The following is a description of a gene set: During acute viral infections, naïve CD8+ T cells differentiate into effector CD8+ T cells and, after viral control, into memory CD8+ T cells. Memory CD8+ T cells are highly functional, proliferate rapidly upon reinfection and persist long-term without antigen. In contrast, during chronic infections, CD8+ T cells become “exhausted” and have poor effector function, express multiple inhibitory receptors, possess low proliferative capacity, and cannot persist without antigen. To compare the development of functional memory T cells with poorly functional exhausted T cells, we generated longitudinal transcriptional profiles for each. Genes down-regulated in CD8 T cells: naïve versus effectors at day 15 after acute infection with LCMV-Armstrong. Human Gene Set: GSE41867_NAIVE_VS_DAY15_LCMV_ARMSTRONG_EFFECTOR_CD8_TCELL_DN from publication Doering TA, Crawford A, Angelosanto JM, Paley MA, Ziegler CG, Wherry EJ (PMID 23159438) studied in species Homo sapiens, and this is the list of marker genes: GTF2B, TBC1D9, INPP5K, ITCH, TECPR1, HIPK1, DDX3X, HPS1, LIPC, POM121, RPS29, PHF20L1, HIP1R, MAP2K6, ANKS3, ARHGAP31, SAFB2, FRS2, ZNF598, EXD2, LMBR1L, DDA1, DMD, PSTPIP1, TFIP11, CAMK4, LAIR1, UAP1, RALGDS, CDYL2, PANK4, BTBD8, TMCC3, MED13, EDC4, ANKS1A, FOXJ2, LDLRAD3, RCHY1, ARHGAP6, ATP13A2, SAG, SIRT7, MTMR12, DNAJB1, HMGXB3, PPP1R37, GEM, MAPK12, CHRAC1, ATP11C, ATAD2B, SLC26A2, SMAD4, NFYC, ZNF691, BTLA, TRMO, AFTPH, PACS1, PCM1, CD300A, MAP4K2, P2RX4, DAB2IP, BSDC1 (BSD domain containing 1), TSPAN32 (tetraspanin 32), FAM53C, TPST2, HNRNPH2, KRAS, CD36, BRI3, MED12, RAMP1, SLC3A2, MPPE1 (NCBI Gene Id 65258), FAM204A, MCOLN2, MIA3, IFT172, INPP5E, AGPAT4, ENTREP3, GPR174, GPD1L, IGLC7, MED31, TFEB, POLM, ZBTB2 (zinc finger and BTB domain containing 2), LRRC57, TMEM31, COQ8A, HERC4, SMG1, RRAS2, ITPKC, ELL3, TCHP, SUB1, ARMCX5, PDE2A, NT5DC1, ITPRID2, PGGHG, GALNT6, RPL37A, STOM, AMN1, MTG2, CDK10, TAX1BP1, CXADR, SETD2, CHD9, PECAM1 (NCBI Gene Id 5175), ZBTB43, AGAP3, ERRFI1 (NCBI Gene Id 54206), HS6ST1, SRGN, GRAP2, KLF7, SRSF3, SAMD9L, ADCY7, MAP3K9, GPR132, C17orf50, SETD1A, TNFRSF1B, MNT, KDM4C, SMCR8, AFP, THRAP3, FHIP1B, APOE, PHRF1, CSGALNACT2, PIP4K2A, ANGPTL1, ACAA2, HNRNPDL, KANSL1L, CRY2, KIT, ARRDC1, UNK, NIPSNAP3A, AKAP7, SMIM14, RSRC2, CD33, NOP10, CNPY3 (canopy FGF signaling regulator 3), ZCCHC9, KLHL15, FAM76B, SLC20A2, BRAP, C15orf39, FAM120AOS, EZH1, JMJD1C, TGFBRAP1, SERTAD2, RNF113A, QKI, RCSD1, CISD2, PTTG1, CPT1A, TESK1, RASGRP3, WBP2, CPSF1, MTSS1, TSGA10, PUM1, FAU, HERC1, RFTN2, SETX, CELA1, CASS4, ARRDC3 (arrestin domain containing 3), BDNF, SUSD5, SARAF, AGO4, ACBD3, ZSWIM8, SDHAF1, RNF103, TAF1C, ENO3, CPNE6